Given this list of marker genes HDAC4, DDR2 (NCBI Gene Id 4921), PDE4D, DNM1, FLNA, RAI1, TGFB3, SNX14, ADNP (activity dependent neuroprotector homeobox), NFIA, AGA, UBE2A, TBL1XR1, IDUA, BRAT1, ZNF711, FLNB, PTCH1, here is a description of the gene set: studied in species Homo sapiens Bizygomatic (upper face) and bigonial (lower face) width greater than 2 standard deviations above the mean (objective); or an apparent increase in the width of the face (subjective). Broad face Human Gene Set: HP_BROAD_FACE